Given this list of marker genes PPP2R1A (protein phosphatase 2 scaffold subunit Aalpha), POLR3A, XPA, LMNA, ERCC6, XPC, ZMPSTE24, ERCC2, ERCC5, ATP6V1E1, ERCC3, TP63, POLH, ALDH1A3, HLA-B, GMNN, ERCC4, IKZF1, DDB2, ATP6V1A, here is a description of the gene set: Entropion An abnormal inversion (turning inward) of the eyelid (usually the lower) towards the globe. Entropion is usually acquired as a result of involutional or cicatricial processes but may occasionally be congenital. species: Homo sapiens Human Gene Set: HP_ENTROPION